Given this list of marker genes HEY2, CITED2 (Cbp/p300 interacting transactivator with Glu/Asp rich carboxy-terminal domain 2), SEC24B, LRP2, JAG1, STRA6, here is a description of the gene set: Human Gene Set: GOBP_PULMONARY_ARTERY_MORPHOGENESIS The process in which the anatomical structures of the pulmonary artery are generated and organized. The pulmonary artery is the artery that carries blood from the heart to the lungs. studied in species Homo sapiens